Given this list of marker genes STAT1, OSR1, HNF1B, ADIPOQ (NCBI Gene Id 9370), BMP4, here is a description of the gene set: Human Gene Set: GOBP_NEGATIVE_REGULATION_OF_KIDNEY_DEVELOPMENT studied in species Homo sapiens Any process that decreases the rate, frequency or extent of kidney development. Kidney development is the process whose specific outcome is the progression of the kidney over time, from its formation to the mature structure. The kidney is an organ that filters the blood and excretes the end products of body metabolism in the form of urine.